Given this list of marker genes IKBKG, FADD, CASP8, TRIM25, MAVS, RIPK1, RIGI, RNF135, IKBKB, CHUK, TRIM4, IFIH1, CASP10, here is a description of the gene set: species: Homo sapiens Reactome Pathway: NF-kB activation through FADD/RIP-1 pathway mediated by caspase-8 and -10 Fas-AssociatedDeathDomain (FADD) and receptor interacting protein 1 (RIP1) are death domain containing molecules that interact with the C-terminal portion of MAVS (IPS-1) and induce NF-kB through interaction and activation of initiator caspases (caspase-8 and -10). Caspases are usually involved in apoptosis and inflammation but they also exhibit nonapoptotic functions. These nonapoptotic caspase functions involve prodomain-mediated activation of NF-kB. Processed caspases (caspase-8/10) encoding the DED (death effector domain) strongly activate NF-kB. The exact mechanism by which caspases mediate NF-kB activation is unclear, but the prodomains of caspase-8/10 may act as a scaffolding and allow the recruitment of the IKK complex in association with other signaling molecules. part of: DDX58/IFIH1-mediated induction of interferon-alpha/beta